Given this list of marker genes Top2a, Dffb, Kdm4a, Acin1, Gper1 (G protein-coupled estrogen receptor 1), Ern2, here is a description of the gene set: The compaction of chromatin during apoptosis. Mouse Gene Set: GOBP_APOPTOTIC_CHROMOSOME_CONDENSATION studied in species Mus musculus